Given this list of marker genes CCNK, POLR2E, CTDP1, GTF2H2, NELFA, POLR2F, GTF2H4, POLR2D, GTF2H3, POLR2J, NELFB, POLR2C, ELOB, GTF2H5, ERCC3, NCBP2, CCNT2, ELOA2, ELOC, CCNH (NCBI Gene Id 902), POLR2I, NCBP1, POLR2K (NCBI Gene Id 5440), NELFE, POLR2H, ELOA, SUPT16H, CCNT1, SUPT5H, POLR2L, ERCC2, SSRP1, ELL, GTF2F2, GTF2H1, POLR2A, GTF2F1, SUPT4H1, TCEA1, POLR2B, CDK9, NELFCD, POLR2G, CDK7, MNAT1, here is a description of the gene set: part of: Transcription of the HIV genome During the formation of the HIV elongation complex in the absence of HIV Tat, eongation factors are recruited to form the HIV-1 elongation complex and P-TEFb complex hyperphosphorylates RNA Pol II CTD. Reactome Pathway: Formation of HIV elongation complex in the absence of HIV Tat studied in species Homo sapiens